Given this list of marker genes CDKN2A, PHF13, SMIM14, NPAS4, BSN, RAPGEFL1, FOXJ3, HNRNPU, CBLN2, SMG7, SLITRK1, DBN1, SRSF1, ACACA, TMCC1, PTK2B, AMMECR1, AKIRIN1, here is a description of the gene set: species: Homo sapiens Genes having at least one occurence of the motif TGCACGA in their 3' untranslated region. The motif represents putative target (that is, seed match) of human mature miRNAs hsa-miR-517a and hsa-miR-517c (v7.1 miRBase). Human Gene Set: TGCACGA_MIR517A_MIR517C